The following is a description of a gene set: species: Homo sapiens Human Gene Set: REACTOME_INTERLEUKIN_2_SIGNALING Interleukin-2 signaling, and this is the list of marker genes: PTK2B, JAK1, IL2RA, SYK, IL2RB, SHC1, STAT5A, JAK3, IL2RG, IL2, STAT5B, LCK